The following is a description of a gene set: studied in species Homo sapiens Any process in which the vacuole is transported to, and/or maintained in, a specific location within the cell. Human Gene Set: GOBP_VACUOLAR_LOCALIZATION, and this is the list of marker genes: SCN11A, TMEM106B, IL4R, SYTL4, RAB3A, VAMP7, RASGRP1, ADORA2B, SLC18A2, GATA1, SNX4, ADGRE2, MILR1, VAMP8, SNAPIN, LAT, SPAG9, CD84, BLOC1S2, PIK3CG, FOXF1, CD300A, RAB44, VPS33B, S100A13, NR4A3, LAMTOR1, PDPK1, LAT2 (linker for activation of T cells family member 2), HDAC6, IL13RA2, RNF167, BTK, BORCS5 (NCBI Gene Id 118426), PLEKHM2, FES, VAMP3, KIF5B, NDEL1, HPS6, BORCS7, IL13, RAC2, CLNK (cytokine dependent hematopoietic cell linker), GATA2, CPLX2, STXBP2, BLOC1S1, RAB34, CHGA, PLA2G3, PIK3CD, RABGEF1, FAM98A, MAP6, FGR, PTGDS, PLEKHM1, UNC13D, CBL, PIP4P1, MYH9, SNAP23, BORCS6, APOLD1, SYK, VAMP2, KIT, STXBP1, DEF8, TFEB, GPR15LG, BORCS8, GAB2, ARL8B, LGALS9, FLCN, LYN, MRGPRX2, IGHE, GRP, SPHK2, KLC2, KXD1, PTGDR, FERRY3, SNX6, VPS33A, FCER1A, FCER1G